Given this list of marker genes RFX5, CIITA, RFXANK, RFXAP, IL12RB1, here is a description of the gene set: Increased susceptibility to protozoan infections, as manifested by recurrent episodes of protozoan infection. Human Gene Set: HP_RECURRENT_PROTOZOAN_INFECTIONS Recurrent protozoan infections species: Homo sapiens